The following is a description of a gene set: The regulated release of bile acid, composed of any of a group of steroid carboxylic acids occurring in bile, by a cell or a tissue. Human Gene Set: GOBP_BILE_ACID_SECRETION studied in species Homo sapiens, and this is the list of marker genes: CLDN2, CES1, MIR33A, ABCB4, SLC51B, TNF, CASR, UGT1A3, NHERF1, ABCB11, SLC51A